The following is a description of a gene set: The chemical reactions and pathways involving glucans, polysaccharides consisting only of glucose residues. studied in species Homo sapiens Human Gene Set: GOBP_GLUCAN_METABOLIC_PROCESS, and this is the list of marker genes: MGAM, RUBCNL, IRS2, WIPI2, IRS1, PPP1R2, WIPI1, GYG2, AGL, POMC, PPP1R3F, ATG3, IL6ST, AKT2, ADCY10, PPP1R1A, PHKB, ENPP1, PPP1R2B, GABARAPL1, STBD1, GCGR, PPP1R3A, IGF1, GYS2, PPP1R3C, GCK, PYGB, PGM2, KHK, MIR15B, MIR1271, PPP1R2P1, WDR45 (NCBI Gene Id 11152), PHKG1, UGP2, PFKM, PPP1CB, GBE1 (NCBI Gene Id 2632), ACADM, GAA, MIR195 (microRNA 195, NCBI Gene Id 406971), INS, NPC1, PHKG2, ATG12, PPP1R3E, AKT1, NHLRC1, PTH, PER2, GSK3B, PHKA2, PYGM, LEPR, COMT, HMGB1, PRKAG3, EPM2AIP1, NR1D1, PYGL, PPP1R3D, SORBS1, PPP1R3B, IGF2, PRKAG2, PHKA1, GSK3A, DYRK2, STK40, GYG1, WDR45B, GRB10, PHLDA2 (NCBI Gene Id 7262), PPP1CA, GNMT, PPP1CC (NCBI Gene Id 5501), EPM2A, INPP5K, RB1CC1, ATG2B, INSR, SELENOS, G6PC1, PPP1R3G, PCDH12, PASK, ATG2A, GYS1